Given this list of marker genes Fzd7, Psenen, Kat2a, Arrb1, Notch1, Psen2, Notch3, Dtx1, Ppard (NCBI Gene Id 69050), Sap30, Fzd5, Dtx4, Ccnd1, Wnt5a, Dtx2, Heyl, Dll1, Lfng, Tcf7l2, Jag1, St3gal6, Skp1, Rbx1, Wnt2, Fbxw11, Maml2, Cul1, Hes1, Notch2, Aph1a, Prkca, Fzd1, here is a description of the gene set: studied in species Mus musculus Mouse Gene Set: HALLMARK_NOTCH_SIGNALING Mouse genes annotated to HALLMARK_NOTCH_SIGNALING based on orthology mappings provided by the Alliance Genome Consortium from publication Howe DG, Blake JA, Bradford YM, Bult CJ, Calvi BR, Engel SR, Kadin JA, Kaufman TC, Kishore R, Laulederkind SJF, Lewis SE, Moxon SAT, Richardson JE, Smith C (PMID 30224793)